Given this list of marker genes GCH1, MTHFD1, MTHFD2, GCHFR, MTHFD2L, ATIC, here is a description of the gene set: Catalysis of the hydrolysis of any non-peptide carbon-nitrogen bond in a cyclic amidine, a compound of the form R-C(=NH)-NH2, in a reaction that involves the opening of a ring. species: Homo sapiens Human Gene Set: GOMF_CYCLOHYDROLASE_ACTIVITY